Given this list of marker genes FOXI1, TANGO2, TG, TSHR, KCNJ10, THRB, NKX2-1, SLC26A4, TREX1, here is a description of the gene set: species: Homo sapiens Condition associated with a raised serum concentration of thyroid stimulating hormone (TSH) but a normal serum free thyroxine (FT4). Compensated hypothyroidism Human Gene Set: HP_COMPENSATED_HYPOTHYROIDISM